Given this list of marker genes Mif, Pik3cb (phosphatidylinositol-4,5-bisphosphate 3-kinase catalytic subunit beta), Epo, Plekho2, Mef2c, Gas6, St6gal1, Clec5a (C-type lectin domain family 5, member a), Thra, Fcgr2b, Il6, Ghsr, Lipa, Pten, Cdkn2a, Itgam, Stat5b, Adam17, Kitl, Nod2, Adipoq, Il18, Cxcr2, Ccr5, Gata1, Hcar2, Ccl5, Apoh, Anxa1, Sirt1, Bcl2, Nf1, Cd44, Fcer1g, Arf6, Selenos (NCBI Gene Id 97368), Gm14461, Ifng, Itpkb, Il3, Snai2, Slc7a11, Stat5a, Trim35, Pik3cd, Bap1, Maea, here is a description of the gene set: Mouse Gene Set: GOBP_MYELOID_CELL_APOPTOTIC_PROCESS Any apoptotic process in a myeloid cell, a cell of the monocyte, granulocyte, mast cell, megakaryocyte, or erythroid lineage. studied in species Mus musculus